The following is a description of a gene set: species: Homo sapiens Human Gene Set: GOCC_RIBONUCLEOPROTEIN_COMPLEX A macromolecular complex that contains both RNA and protein molecules., and this is the list of marker genes: SYF2, DICER1, CACTIN, MIR124-2, RIOK3, PA2G4, MIR29B2, POP5, MRPS27, RPL41, FBLL1, DDX5, RNVU1-7, MIR615, MIR224, SART1, EIF3B, MIR215, MIR125B2, DKC1, MIR130A, DDX3X, MIR145, ZNHIT3 (zinc finger HIT-type containing 3), NOL10, RRP1B, FRG1, MIR764 (microRNA 764), MIR181A2, MIR345, PPP1R8, RNF113A, EMG1, MIR611, RPS19BP1, MIR331, MIR17HG, MIR576, MRPS14, MRPL9 (mitochondrial ribosomal protein L9), LSM6, TRA2B, MIR339, RBM45, UPF1, GCFC2, MIR3529, MIR922 (NCBI Gene Id 100126321), MIR3120, MIR154, APOBEC3F (NCBI Gene Id 29762), MIR19B1, MIR361, MIR197, RNVU1-15, PDCD11, HSF1 (NCBI Gene Id 642255), MRPL42, RPL13A, MIR628, MIR15B, PRORP, CTNNBL1, MRPL51, TOP2A (DNA topoisomerase II alpha), POP1, PABPC3, NOB1, RBM41, MIR92A1, CRNKL1, RPL26L1, WDR12, CELF2, NSUN3, PABPC5, RPL6, RPS10P5, RRP7BP, MIR489, SF3B4, SNW1, EIF4A3, RPL27A, RPL4, XAB2, MRPS25, MPHOSPH10 (M-phase phosphoprotein 10), RPL17, BOP1, UTP14A, HOXA10-AS, MIR219A2, ATXN2, PIH1D2, NUP98, EIF3D, PHF5A, SNRNP27, UTP15, SMG5, MIR1287, ZFP36L2, PPIL2, CDC40, MRPS33, DCAF13, MIR553, MIR148B, RALY, MIR601, MIR542, PRKDC, EIF1B, RNU5F-1, U2AF1L4, MIR18A, MIR135A2, MIR194-2, MIR711, SMNDC1, PTGES3 (NCBI Gene Id 10728), TGS1, MIR137, HSPA1B, MRPS24, CIRBP, MIR543, LSM11, MIR577, MIR143, MIR212, CWF19L1, SF3B5, BUD13, FBL, MIR216A, MRPL2, RNU1-4, EXOSC10, MIR101-2, MIR103A2, LRPPRC, MIR1827, DYRK1A, PLRG1, SRP14 (NCBI Gene Id 6727), ELAVL2 (ELAV like RNA binding protein 2), MIR103A1, MIR487B, MIR1237, TDRD1, WRAP53, RPS28, SSB, MIR1-1, MRPL28, MIR15A (microRNA 15a), RPLP0P6, RPS2, MIR618, PABPC4, SNRNP200, SRP19, API5, PRPF38A, MIR485 (NCBI Gene Id 574436), MIR1275, MIR504, MIR122, MIR125A, SNRPF, MIR1227, SF3B2, MIR500B, SNIP1, HNRNPC, MIR147B, MIR548A3, MIR548H2, MIR580, IGHMBP2, MFAP1, MIR211, MIR873, MRPL36, EEF2, SNRNP48, HNRNPA0, RBMX, DAP3, MRTO4, LSM1, MIR874, PWP2, MIR190A, RPS26, TRMT10C, MIR550B1, MRPL46, MRPS18B, CSNK1E, MIR365A, NOL6, U2AF1, MIR592, MIR887, MIR338, FTSJ3, MIR377, MIR375, MIR200B, MIR19A, MAGOH, MIR1265, MIR761, MIR329-2 (NCBI Gene Id 574409), NGDN, MIR210 (microRNA 210), RNU6-1, MEG3, YBX1, SF3B3, DCP2, RPL11, U2SURP, MIR631, MIR552 (microRNA 552), CELF1, MIR33A, MIR539, NEAT1, RPL36A (ribosomal protein L36a), MIR382, JRK, MIR676, RPS3, MIR134, PRKRA, MIR320D2, HNRNPU, TRA2A, MRPL3, MIR337, MIR3065, MIR424, DHX32, MIR23AHG, RPS27, MIRLET7C, MRPL17, MIR219A1, ALYREF, RNF113B, PRPF39, RPS24, MIR323A, MIR626, RRP15, MIR3677HG, MIR454, RBM14, BRCA1 (BRCA1 DNA repair associated), CCDC12, MIR499B, MIR1912, PRKRIP1, MIR636, MIR204, MIR744, TEFM, MIR1208, MIR135A1, MIR604, XPO5, DNM3OS, PATL2, EIF3K, TXNL4B, RN7SL2, PRPF18, RPS11, MRPL16, MIR132, MRPL20, MIR23A, MIR155, MIR205, MIR448, ARFGEF1, PRPF4, RPS4Y2, MIR26A1, TXNL4A, MIR146B, MIR29A, SRSF1, RPL21 (NCBI Gene Id 6144), GAPDH, SNRPN, SNORA63, RBM17, SNRPA1, EFTUD2, RPS19, SNRPD1, MRPL37, RCL1, DDX6, MRPL54, HNRNPA2B1, MIR544A, DHX16, MIR93 (microRNA 93), MIR320B2, HNRNPK, RBMS1, DIMT1, MIR487A, MIR152, CELF4, CPSF3, MIR642B, SMU1, MIR1180, MIR370, MIR138-1, MIR29C, SNRPB2 (NCBI Gene Id 6629), NOP14, RBMS3, RBM3, SRFBP1, EFL1, MRPL11, SREK1, EIF1, MIR455, MIR589 (NCBI Gene Id 693174), MRPS18A, UTP14C, ACTN4, MIR181B2 (NCBI Gene Id 406956), RNPC3, UTP11, TIA1, GJD2-DT, MIRLET7I, TEP1, MIR29B1, MRPL21, CASC3 (CASC3 exon junction complex subunit), SNORA73A, MIR505, ACD, PRPF3, SECISBP2, POP4, MIR548M, MIR96, PPIH, SRP54, C9orf78, DHX15, DDX1, YJU2B, MRPL50 (mitochondrial ribosomal protein L50), MIR219B, MRPS18C, LSM8, RPS17, MIR128-1, HSPA1A, MIR16-1, WDR3, MIR655, LSM7, MIR1307, EIF3F, MIR494, HTATSF1, IGF2BP1, MIR621 (NCBI Gene Id 693206), MIR133A1HG, WDR36, SF3A1, MIR770, BHLHE40-AS1, ARMC7, MEPCE, MIR578, MIR323B, HNRNPA3, ZCCHC17, ZFP36, MRPL43, MIR632, RUVBL2, RPF1, MIR936, NUP62, UTP6, MIR31, MIR541, MIR362, RPL5, IK, MIRLET7G, MRPS22, MIR24-1, RBMS2, RIGI, MIR642A, MIR199B, MIR940 (NCBI Gene Id 100126328), MIR200C, MRPL18, MIR346, MIR199A1, RPS23, RPL18A, POP7, MRPS9, CWC25, RPS21, EIF3I, MIR548AJ2, ERG, RPL14, ESRP1, MIR140, MIR107, TFIP11, RPL37AP8, PCBP4, SF3B6, HEXIM1, AGO3, MIR153-2, PUF60 (NCBI Gene Id 22827), ACTB, MIR200A, HNRNPH3, SLBP, MIR572, TOP2B, CPEB1, MIR330, MIR190B, MIR593, ZRSR2, RPS6, SF3A2, MIR24-2, RPL12, MIR22HG, HNRNPL, CELF3, MIR376A2, RPL35, ZCRB1, HNRNPCL2, MIR609, MIR499A, MIR3142HG, MIR126, SNRPD3 (small nuclear ribonucleoprotein D3 polypeptide), MIR103B2, SPACA6-AS1, RO60, MIR133A1, NUFIP1, MRPL40, RNVU1-17 (NCBI Gene Id 101954269), UTP23, ZNF827, MRPS7, PABPC1, SECISBP2L, MIR491, EIF3M, DDX23, SF3A3, MIR146A, MIR581, IVNS1ABP, RPS15, MIR296, LIMD1, RNVU1-3, RPL34 (ribosomal protein L34), MIR30B, RBMXL1, PRPF31, HNRNPCL1, ELAVL4, UTP20, LSM3, HNRNPF, SLU7, MRPS11, MIR342, PIN4, RPPH1, RHEB, RACK1, RPS8, MRPS2, MIR324 (microRNA 324), RNU6-9, DHX8, SND1, RRP7A, USP39, RNU5A-1, RPL39, MRPL41, MIR133A2, MIR450A1, XPO1, MIR129-1, AGO2, RPL28, RPL27, MVP, PES1, PPAN, NOP9, ZC3H14, RPS18, LSM4, RNVU1-8, HNRNPA1L3, MIR556, RPS5, MRPL39, MIR877, MIR335, MIR365B, MRPS30 (NCBI Gene Id 51331), MIR411 (NCBI Gene Id 693121), PRPF38B, RNVU1-19, RPSA2, RNVU1-14, TAF9, ERI1, MRPL15 (mitochondrial ribosomal protein L15), MIR20B, MIR938, MIR500A, DQX1, SNRPC, EIF3E, RPS16, NVL (NCBI Gene Id 4931), TSSC4, GEMIN2, MIR9-2, KRI1, RIOK2, MIR369, GNL3L, ISY1, SRP9, KRR1, TERC, TARBP2, RPL29, MIR328, RPS27A, MIR1183, ZRSR2P1, MIR1197, MIR942, MIR582, MIR106A, MIR202, MIR486-2, MIR100, AKAP17A (NCBI Gene Id 8280), LSM14A, MIR376C, MIR144, MIR450B, RBMY1E, RRP36, WEE2-AS1, MIR135B (microRNA 135b), NOP10, RPS13, MRPS21 (mitochondrial ribosomal protein S21), RBM28, GPKOW, MIR196B, MIR125B1, MIR302D, MIR376B, MIR550A3 (NCBI Gene Id 100616354), MIR32, RPL8, DNTTIP2, PTCD3, ZNHIT6, MIR653, MIR889, MIR101-1, NOC2L, SNRPD2, MIR30E, MAK16, MIR550A2, MIR26B, RNF135, MIR326, PPIL3, RPL19, UTP18, NOL7, MRPL24, YJU2, MIR1-2, RBM44, MIR551A, WBP4, MIR600, MIR934, CWC22, MIR3074, MIR584, RN7SK, MRPL34, MIR548H4, LUC7L, MIR148A, EIF3G, MIR302A, HNRNPD, RPS12, LUC7L3, MIR320D1, MIR300, MIR320E, UTP3, CELF5, NFATC2, MIR187, MRPL45, TBL3, MRPL48, FMR1, MIR320C1, NSA2, ZC3H18, LARP4, MIR199A2, MIR196A2, MIR423, TIFAB, PABPC4L, SUGP1, MIR221, DDX41, ENSG00000283175, MIR10B, RBM42, MIR665, MRPL32, MRPL44 (NCBI Gene Id 65080), RPS14, EIF3C, PABPN1, XIST, MIR671, RPS4Y1, RPS4X, MIR9-3, TRIM21, SNRNP25, PCBP3, MIR18B, MIR320C2, MRPS26, RPLP0, MRPS10, SNRPG, HNRNPR, PABPC1L2A, HNRNPDL, PARP4, MRPS5, MDN1, RPL13AP3, MIR558, ELAVL3, MIR30C1, MTREX, RPS3A, SCNM1, HNRNPM, CELF6, RBM8A, RPP14, RPL26, PIH1D1, MIR203A, MIR367, RPL3 (ribosomal protein L3), SRRT, ADAR (adenosine deaminase RNA specific), EPRS1, LUC7L2, MRPL47, RN7SL1, MIR99B, ZMAT2, LSM5, MRPL35, MIR99A (NCBI Gene Id 407055), MRPL1, PNO1, L1TD1, CWC27, MIR16-2, MRPL13, MIR605, MIR640, RBMY1A1, RNU11, RPS25, MIR1253, PRP4K, SLIRP, EIF2S1, RNVU1-2A, EIF3L, SNRNP35, NCBP1, SNRPB, RBM22, UTP4, PPIL1, MIR490, AURKAIP1, MRPS28, MRPL27, MIR502, MIR138-2 (microRNA 138-2), MRPS17, EBNA1BP2, GRSF1, MIR198, MIR136, MRPL14, MIR498, WDR46, PABPC1L2B, RNU5D-1, MIR920, SNRPA, HNRNPLL (NCBI Gene Id 92906), EIF3CL, EIF2A, RPL30, DNAJC17, PPIE, LTV1, GADD45GIP1, MIR1249, RPSA, RPL38, MIR1185-1, HNRNPUL1, RPS29, MIR643, RPL36AL, MIR1185-2, MRPS31, MIR1251, MIR548H3, MIR503, MIR20A, EIF1AX, GAR1, NHP2, SRA1, MIR192 (NCBI Gene Id 406967), AAR2, MIR203B, TNRC6A, MIR103B1, PABPC1L, AQR, MIR329-1, JAKMIP1, MIR598, MIR191, DHX40, XRCC5, MIR147A, MRPS34, SNRPE, NAF1, SLX9, MIRLET7A2 (NCBI Gene Id 406882), SF1, MIR184, NOC4L, MIR206, MIR7-1, HNRNPA1L2, SNAP25-AS1, MIR550B2, HNRNPH1, PPWD1, DHX38, DDX17, AKAP8L, RPL10A, HNRNPA1, ILF3, MIR137HG, RPL18, MIR222, MRPL12, MIR495, RBMY1J, MIR10A, RPL10L, MRPL19, WDR74 (WD repeat domain 74), RNVU1-6, RPL37A, DHX29, LSM2, RPL39P5, UBA52, SF3B1, MIR302B, CDC5L, MIR185, PCBP1, RRS1, HSPA8, ESRP2, DYRK2, SUZ12, BMS1, RNVU1-1, WDR83, MIR17, BYSL, MIR575, DHX9, LSM14B, MIR624, MIR30A, RNU2-1, HSD17B10 (NCBI Gene Id 50828), MRPL53, MIR186, GTF3C1, MIR590, RNU4ATAC, MIR1306, MIR27B, PRPF40A, EEFSEC, MIR181A1, MIR214, KHDC4, RNU4-1, MIR573, MIR612, UTP25, FAU, RPL13, MIRLET7D, SMG7, HEATR1, AATF, SNRNP70, LGALS3, SRP68, NOP58, WAC, RPL24, MIR656, RNU5B-1, MIR661, MIR450A2, DDX46 (DEAD-box helicase 46), RPL15, MIR98, MIR22, MIR484, SNORA62, ZNF830, PTBP2, SRRM1, MIR425, MIR128-2, RPL10, MIR218-1, RBMX2, MIR497, RPP40, MIR302C, MIR939, MIR496, HNRNPAB, MIR1296, MIR26A2, RBMY1D, RPL23, TTF2, RPLP1, PRPF19, RPP25, DHX37, MAGOHB, MIR33B, MRPL57, RBM12, MIR183, NPM1, SNU13, PRPF40B, EIF3H, GPATCH1, RPL36, MIR550A1, MRPL49, AGO4, MRPS23, MIR1178, MIR3184, MRPL55, DAZAP1, RPS6KL1, DDX39B, ZFP36L1, MIRLET7F1, NIP7, CWF19L2, HNRNPH2, RPL39L, MIR1207, SART3, IQGAP1, TERT, MIR452, AGO1, RBM48, MIR105-1, MIR548AA2, RPS9, MIR586, RNU5E-1, SRRM2, RPL22L1, MIR223, ESS2, SYNCRIP, RPL31, DHX35, MIR648, NSUN4, MIR141, BUD31, MTERF4, MIRLET7BHG, RPL37, ZNF622, MRPL30, RPL35A, MIR142, SMG6, MIR19B2, PHAX, RNVU1-4 (NCBI Gene Id 101954268), MIR551B, MIR155HG, MIRLET7A3, MIR106B, MIR383, MRPL33, GEMIN4, MIR23B, CARMN, CHCHD1, CBX5, ZMAT5 (zinc finger matrin-type 5), ILF2, MIR124-1 (NCBI Gene Id 406907), MIR218-2 (NCBI Gene Id 407001), MIRLET7F2, MIR92A2, MIR433, MIR3591, APOBEC3G, SNORA74A, RPS7, RPL32, RPP30, PNN, BCAS2, MIR9-2HG, RBM12B, MIR21, RPS15A, RPL9, MIR105-2, MIR216B (NCBI Gene Id 100126319), MIR7-3, MIR488, MIR124-3, RN7SL3, MRPS35, ELAVL1, EIF3A, RPL22, MIR607, MIR548AZ, MIR149, MRPS15, PRPF8 (NCBI Gene Id 6108), RPL3L, RPS27L, CD2BP2, MIR153-1, MRPL38, RBMY1B, RBMXL2, U2AF2, MIRLET7A1, CRIPT, NCL, LRRK2, RBM5, CLNS1A, EIF4E, RPP25L, PCBP2, RNU4-2, FCF1, RPL7A, WDR75, MRPL10, LSM10, MIR7-2, LARP6, MIR3179-2, MIR657 (NCBI Gene Id 724027), MIR195, MIR139, MIR299, C1orf131, MIR320A, RPS10, MIR876, RBMY1F (NCBI Gene Id 159163), MIR196A1, MIR381, SRP72, NOP56, CWC15, DDX42, IMP4, RUVBL1, MIR25, RPL23A, MIR569, EIF3J, MIR150, ZCCHC8, TAF12-DT, MIRLET7B, CPSF6, RRP9, MIR320B1, RPS20, MIR944 (microRNA 944), MRPL23, RRP1, PDCD7, SNRPGP15, MIR27A, MIR181C, MIR486-1 (microRNA 486-1), TTC9-DT, MRPL22, MIR501 (microRNA 501), MIR675, RPP38, PRPF6, MIR625, RPL7L1, NAT10, MIR548D2, MIR409, MIR217, MIR30C2, JMJD6, MIR127, MIR194-1, RNU6ATAC, MIR548X2, IMP3, RPP21, MIRLET7E, MRPL4, MIR9-1, MIR30D, NSRP1, RIOK1, LARP7, RPL7, WDR43 (WD repeat domain 43), MRPS6, MIR29B2CHG, MRPS12, MKRN3, RPLP2, MRPS16, MRPL52, RNU6-7, MRPL58, SNRNP40, MIR410, MIR133B, MIR129-2